The following is a description of a gene set: Neighborhood of CSNK1D Human Gene Set: GCM_CSNK1D Neighborhood of CSNK1D casein kinase 1, delta in the GCM expression compendium studied in species Homo sapiens, and this is the list of marker genes: RNF216, RMDN3, UPF3A, CHMP4B, TBC1D15, UBR5, EVI5, PIP4P1, GPR107, GPR153, ACTR10, PHF10, PRRC2C, TMEM248, ZNF644, KANSL3 (KAT8 regulatory NSL complex subunit 3), RAB10, SAP130, SRRM2, UBQLN2, CSNK1D, TMEM30A, UBQLN1, PJA2, BPNT2, ARFGAP1, ZFAND3, YTHDF1, TAB2, VPS52, FBXL5, FAM168B